The following is a description of a gene set: Human Gene Set: GSE24574_BCL6_LOW_TFH_VS_TCONV_CD4_TCELL_DN from publication Kitano M, Moriyama S, Ando Y, Hikida M, Mori Y, Kurosaki T, Okada T (PMID 21636294) Genes down-regulated in BCL6 low follicular helper T cells versus T conv cells. We found that a number of Tfh cells downmodulated BCL6 protein after their development, and we sought to compare the gene expression between BCL6-hi Tfh cells and BCL6-low Tfh cells. studied in species Homo sapiens, and this is the list of marker genes: PCBD1, GAPDH, MIF, MAT2A, HTATIP2, PHGDH, ENO2, LGALS1, TUBG1, ORC4, FKBP2, EIF4A1, SNRPC, MYBL2, YWHAE, GSTP1, SORD, FAH, PSMB9, FANCL, MRPL19, CDK2, FPGT, BDH1, ARHGAP19, RTL8C, COX8A, PNP, CYB5B, MELK, XPOT, SLC29A1, TBCE, DUSP4, DSTNP2, AURKA, TNFSF10, H2BC10, RPA3, PRDX1, RAD51AP1, ECHS1, BLM, IPO7, SLC27A2, TYMS, TRAIP (TRAF interacting protein), NUDT21, ADSL, BUB1B, IDH3G, HAX1, TIAM1, ACTG1, YIF1A, HMGCL, GSTA4, LDHA, MRPS12, KIFC1, H4C3, AHCYL1, MRPL28, TXN (thioredoxin), HIRIP3, MCM4, RAD54L, MAP2K3, SEC23IP, TNFRSF9, NDUFB8, CYP1B1, LCMT2 (leucine carboxyl methyltransferase 2), ATP5MC1, CENPF, FANCI, PFAS, PRPS2, THOP1, POLD3, FAM98A, UMPS, DBI, CKS1B, PLK1, EPRS1, FAM161A, ACTA1, NAA10, TEAD4, PRIM1, CRYZ, STX11, SRR, SNRPA, PARP1, SLC1A5, ST14, TM7SF2, S100A11, NCAPD2, FSCN1, MRE11, IPO5, FADD, CRYGD, SCD, TTF2, TOP2A, COX6A1, EIF3I (eukaryotic translation initiation factor 3 subunit I), PMVK, SERPINE2, VCP, HMGN4, ENO1, AIFM1, ESPL1, TOMM40, PSMD14, RFC4, HOMER1, EEF1E1, IMMT (NCBI Gene Id 10989), AARS1, CETN3, CHAF1A, GALE, MCM3, PLK4, SRM, PITPNB, CLIC1, AP2S1, TXLNA, ORC1, CCT6A, MTHFD2, IDH2, MCM2, PSMD13, EZH2, SHMT2, FABP5, EBP, UBE2M, UNG, NRAS, TIMM17B, CPOX, TRAF1, CTNNA1 (NCBI Gene Id 619480), HADH, TXN2, TMED9, HSD17B10, SMS, NEFH, PLXNA3, NIPSNAP1, PYCR1, CORO1A, SIT1, HMGN2, TTK, TP53, NFIL3 (nuclear factor, interleukin 3 regulated), RPA2, PSMA5, CSNK2A2, BAG2, EBNA1BP2, PKM, IMPDH2, PEA15, MTHFD1, CDC7, DFFA, EIF2S1, AURKB, ECI1, GINS1, GOSR2, GCLM, GOT1, XCL2, GGCT, PPID, GTF2E2, SKAP2, GPX1, ATP5MC3, COMT, BCAT2, CDK4, HMMR, CENPS, ZWINT, BHLHE40, DHFR